Given this list of marker genes RGS9, PITX1, RNF19A, FAH, TMEM121B, NID1, DENR, WASHC4, MTMR7, ARG2, PCP4, ACBD3, TMEM54, GRIK1, TAS2R1, LTA, NOTCH2, KATNA1, SMC5 (NCBI Gene Id 23137), SLC25A29, MARCO, RNF149, SOWAHC, MEF2A, CBS, LGALSL, GOSR1, EMID1, APBB2, FAM50B, PCARE, UPP1, LY75, BARX1, CALB1 (calbindin 1), FABP3, SYPL1 (synaptophysin like 1), PTPRE, IKBKB, NDP, CACNA1B, NIBAN1, MAPKAPK2, RAD18 (RAD18 E3 ubiquitin protein ligase), CNN1, ATP9B, DNAJB12, PAFAH1B1, TBC1D13, KANK2 (NCBI Gene Id 55598), SATB2, PTPRA, RNMT, ATF3, HPGD, CCDC71L, PLAAT3, IGF2BP1, CCL1, DLGAP4, AQP4, CD40, LAMB1, ATP1A1, AGFG1, ELL2 (elongation factor for RNA polymerase II 2), CD96, ESRRG, PDE4B (NCBI Gene Id 5142), RUSC2, IGDCC3, STAT2, PRDX5, MAFF, NMD3, BCAM, MUC13, PRDX1, GRPR, CEBPD, SERPINB7, CCNT2, KMT5A, SERPINE1, FST, SMAD2, ICOSLG, UBE2L6, DTX2, TRPC5, ZBTB17, DND1, FCER2, CHMP7, MTF2, BLZF1, QPRT, IL23A, PLS3, PLCZ1, IRS2, FPR1, ZNF212, ELAPOR1, P2RY2, MAPKAPK5, MYOZ1, MFSD11, ZFPM2, KATNBL1, JARID2, IL10RB, FRMD6, FOXG1, EGR3, BOLL, CXCL10, LDHC, TOR1AIP2, MTMR14, IL1RN, TMCO3, EMC7, CLCN1, CSRP2, BBLN, OLR1, FCGR2B, C2orf76, POGLUT1, NOMO1, COX4I2, BCR, HGD, SPRTN, CPD, NAA38, APIP, IL36A, PSMD7, PTPRJ, WARS1, RHBDL3, METAP1, PSMC6, IER3, ZBTB7A, STAT5A, MSLN, SFSWAP, KCNQ5, FOXN1, CDR2, MTDH, KCNH7, MYCN, ZFP30, OASL, HMX2, RUFY3, HDGF, WBP2, VTN, EMC6, WASF3, TSPAN33, GCH1, ACTR10, CA5A, EN1, RAB30, UBLCP1, LMAN1L, PPP1CB, SRP54, NHERF1, DUSP2, ATXN7L1, GMPPB, MACROD2, PLSCR1, CFHR2, TGM2, PPBP, CSDE1, GPR137B, L3HYPDH, TMEM243, STARD5, DUSP11, CSF3R, SHISA2, ETS2, LY6G6D, ALPK2, IFT81, CCR8, SOX14, PSMA3, CTTN, here is a description of the gene set: mouse primary BMDCs were stimulated with tlr ligands and gene expression changes were profiled on Affymetrix arrays studied in species Homo sapiens from publication Amit I, Garber M, Chevrier N, Leite AP, Donner Y, Eisenhaure T, Guttman M, Grenier JK, Li W, Zuk O, Schubert LA, Birditt B, Shay T, Goren A, Zhang X, Smith Z, Deering R, McDonald RC, Cabili M, Bernstein BE, Rinn JL, Meissner A, Root DE, Hacohen N, Regev A (PMID 19729616) Genes down-regulated in comparison of control dendritic cells (DC) at 4 h versus those stimulated with Gardiquimod (TLR7 agonist) at 4 h. Human Gene Set: GSE17721_CTRL_VS_GARDIQUIMOD_4H_BMDC_DN